The following is a description of a gene set: species: Homo sapiens from publication Gautam P, Hamashima K, Chen Y, Zeng Y, Makovoz B, Parikh BH, Lee HY, Lau KA, Su X, Wong RCB, Chan WK, Li H, Blenkinsop TA, Loh YH (PMID 34584087) Occular cell types curated from Gautam and Hamashima et al. Multi-species single-cell transcriptomic analysis of ocular compartment regulons Human Gene Set: GAUTAM_EYE_CORNEA_CONJUNCTIVAL_CELLS, and this is the list of marker genes: CAMSAP1 (calmodulin regulated spectrin associated protein 1), C1orf116, SPAG9, HLA-B, CTSS, LAD1, MPP7, SPRR1B, RASSF5, RAB27B, EPHB3, NUPR1, BID, PTPN13, MALL, RDH13, ATP5F1E, CEACAM6, INPP1, KRT24 (keratin 24), RPLP0, PDLIM5, CRYBG2, RPL28, HMOX1, SCNN1A, MUC4 (NCBI Gene Id 55804), ARF6 (ADP ribosylation factor 6), GLTP, RCOR1, CBX6, EIF6, TOB2, LINC00511, TMEM154 (NCBI Gene Id 201799), CEACAM1, SPSB1, MAOA, MACC1, MUC1, PLAAT4, GALNT3, ST3GAL4, NT5C2, KRT7, MIDN, MAP3K8, BAIAP2, RALGDS, H2BC12, CDKN1A, CCDC6, WASF2, COX7A2, CRB3, SH3BGRL3, AKR1A1, RPS29, MIR200CHG, RERG, MSMB, DNAJB6, P2RY2, NIBAN2, TC2N, TMEM165 (transmembrane protein 165), TSTD1, PRELID1, H2AJ, DAPP1, CFLAR, RIOK3, RPL41, F2RL1, B3GNT5, HMGCS1, ZNF593, PDCD4, ATP10B, STX11, BIK, SELENOH, CLIC1, NBEAL2, CD82, LDLR, IRF2BP2, OCLN (NCBI Gene Id 4950), PPL, CTTN, YWHAZ, MYCL, IFI27, H2AC18, RHCG, FAM83A, H2BC4, SULT2B1, BICDL2, SLC25A5, TTC9, TMED3, CDH1 (cadherin 1), EMP2, MT-ND1, FRMD8, PPDPF, SPINT1-AS1